The following is a description of a gene set: Vasopressin regulates renal water homeostasis via Aquaporins Mouse Gene Set: REACTOME_VASOPRESSIN_REGULATES_RENAL_WATER_HOMEOSTASIS_VIA_AQUAPORINS studied in species Mus musculus, and this is the list of marker genes: Gng3, Gng12, Gnb5, Gng5, Gng4, Gng11, Avpr2, Gng10, Gng8, Gnas, Prkacb, Gngt1, Prkaca, Aqp2, Avp, Rab11a, Gnb4, Rab11fip2, Gng7 (guanine nucleotide binding protein (G protein), gamma 7), Gnb1, Myo5b (myosin VB), Aqp3, Prkar1a (NCBI Gene Id 80472), Aqp4, Gnb2, Prkar1b, Gnb3, Aqp1, Gngt2, Gng13, Gng2